Given this list of marker genes Ppp2cb, Strip2, Ppp2ca, Mob4, Strip1, Pdcd10, Sike1, Slmap, Cttnbp2nl, Strn4, Stk26, Strn3, Ppp2r1a, Strn (striatin, calmodulin binding protein), Stk25, Stk24, Cttnbp2, here is a description of the gene set: studied in species Mus musculus Mouse Gene Set: GOCC_FAR_SIN_STRIPAK_COMPLEX A conserved protein phosphatase type 2A complex which contains a protein phosphatase type 2A, a protein phosphatase regulatory subunit, a striatin, an FHA domain protein and other subunits (at least six proteins). In fission yeast this complex negatively regulate the septation initiation network at the spindle pole body.